The following is a description of a gene set: studied in species Mus musculus Mouse Gene Set: GOBP_CELLULAR_RESPONSE_TO_CAFFEINE Any process that results in a change in state or activity of a cell (in terms of movement, secretion, enzyme production, gene expression, etc.) as a result of a caffeine stimulus. Caffeine is an alkaloid found in numerous plant species, where it acts as a natural pesticide that paralyzes and kills certain insects feeding upon them., and this is the list of marker genes: Chek1, Ryr1, Tmem38a, Selenon, Slc8a1, Casq2, Gstm7, Tmem38b (NCBI Gene Id 72005), Cacna1s, Ryr3, Ryr2